The following is a description of a gene set: Mouse Gene Set: CUI_T_CELL_GD_OSM_RESPONSE_UP studied in species Mus musculus from publication Cui A, Huang T, Li S, Ma A, Pérez JL, Sander C, Keskin DB, Wu CJ, Fraenkel E, Hacohen N (PMID 38057668) Cytokines mediate cell-cell communication in the immune system and represent important therapeutic targets. A myriad of studies have highlighted their central role in immune function, yet we lack a global view of the cellular responses of each immune cell type to each cytokine. To address this gap, the authors created the Immune Dictionary, a compendium of single-cell transcriptomic profiles of more than 17 immune cell types in response to each of 86 cytokines (>1,400 cytokine-cell type combinations) in mouse lymph nodes in vivo. A cytokine-centric view of the dictionary revealed that most cytokines induce highly cell-type-specific responses. For example, the inflammatory cytokine interleukin-1β induces distinct gene programmes in almost every cell type. A cell-type-centric view of the dictionary identified more than 66 cytokine-driven cellular polarization states across immune cell types, including previously uncharacterized states such as an interleukin-18-induced polyfunctional natural killer cell state. Genes positively differentially expressed in cell type: γδ T cell upon treatment with cytokine: OSM in mouse lymph nodes in vivo., and this is the list of marker genes: Bcl2 (B cell leukemia/lymphoma 2), Sell, Ddit4, Pdcd4, Apobec3, Pmepa1, Gpr65, Tsc22d3, Ccnd3, Nedd4, Dtx1, Xaf1, Acp5